Given this list of marker genes SNAPC4, MYOD1, SNAPC1, ZNF143, ZC3H8, ELL, ICE2, SNAPC3, LARP7, CDK7, ELL2, SNAPC5, CC2D1A, ELL3, ICE1, MEPCE, here is a description of the gene set: Human Gene Set: GOBP_SNRNA_TRANSCRIPTION_BY_RNA_POLYMERASE_II The synthesis of small nuclear RNA (snRNA) from a DNA template by RNA Polymerase II (Pol II), originating at a Pol II promoter. species: Homo sapiens